The following is a description of a gene set: Human Gene Set: GOBP_VITAMIN_D_BIOSYNTHETIC_PROCESS The chemical reactions and pathways resulting in the formation of vitamin D, any of a group of related, fat-soluble compounds that are derived from delta-5,7 steroids and play a central role in calcium metabolism. Specific forms of vitamin D include calciferol (ergocalciferol; vitamin D2) and cholecalciferol (calciol; vitamin D3). studied in species Homo sapiens, and this is the list of marker genes: CYP2R1, CYP3A4, IFNG, NFKB1, CYP27A1, GFI1, CYP27B1, CYP24A1, TNF, SNAI1, SNAI2